The following is a description of a gene set: species: Mus musculus Any process that modulates the rate, frequency, or extent of the spindle checkpoint, a cell cycle checkpoint that delays the metaphase/anaphase transition until the spindle is correctly assembled and oriented, and chromosomes are attached to the spindle. Mouse Gene Set: GOBP_REGULATION_OF_SPINDLE_CHECKPOINT, and this is the list of marker genes: Ska1, Mad2l1bp, Aurka (aurora kinase A), Tpr, Zwint, Lcmt1, Xrcc3, Pcid2, Knl1, Ccnb1-ps, Hsf1, Gen1, Usp44, Dusp1, Dync1li1, Aurkb, Prap1, Birc5, Cdca8, Ska3, Mad2l1, Incenp, Ccnb1, Anapc15, Mad1l1, Prpf4b, Anapc15-ps, Ndc80 (NDC80 kinetochore complex component), Cdk5rap2 (CDK5 regulatory subunit associated protein 2)